The following is a description of a gene set: species: Homo sapiens Effects of SOCS3 on the transcriptional response of bone marrow-derived macrophages to IL-6. Fetal liver cells from SOCS3+/+ or SOCS3-/- embryos were used to reconstitute recipient mice. Donor derived bone marrow from these mice was differentiated to macrophages. Macrophages were either unstimulated, or stimulated for 100 or 400 minutes with 10 ng/ml IL-6. Human Gene Set: GSE411_UNSTIM_VS_100MIN_IL6_STIM_SOCS3_KO_MACROPHAGE_UP Genes up-regulated in macrophages with SOCS3: untreated versus IL6 for 100min. from publication Lang R, Pauleau AL, Parganas E, Takahashi Y, Mages J, Ihle JN, Rutschman R, Murray PJ (PMID 12754506), and this is the list of marker genes: WDR48, NCKIPSD, APBB1IP, AGL, OTULINL, SIAH1, NT5C, POLI (NCBI Gene Id 11201), ARHGEF6, TRIM65, OPA1, INTS7, IRGC, SLC43A2, PPP1R3F, S100A11, NFS1, HLA-DRB1, MRPS35, BIVM, DNASE1L3, RIC8B, ST6GALNAC3, NUDT6 (NCBI Gene Id 11162), AGRN, MAF1 (NCBI Gene Id 84232), BORCS7, TRRAP, RPS6KA5, SAV1, MDN1, PRPSAP2, RGL2, POLN, SBSN, ZNF236, FES, ORC3, USF2, EEF1AKMT2, ZKSCAN8, TBC1D19, IL4R, MYO9B, CRTC1, ZCCHC24, CHD9, USE1 (unconventional SNARE in the ER 1), TXNDC16, TESK2, C11orf68, TNK2, TUT4, PHF2, COA6, MRGPRE, C3orf33, EPB41L2, BRD9, NEB, PEX11G (peroxisomal biogenesis factor 11 gamma), HPSE, ZNF157, AMDHD2, NUDT16, DCP2, TSN, ANP32A, TCEA2, PPM1E, B3GNT8, ZNF518B, FAM120AOS, CORO1B, MED10, STX7 (NCBI Gene Id 8417), PIGN, TP53BP1, LONRF1, DNAL1, SDCCAG8, ASH1L, SCOC, AP1G2, CCDC28A, DTNBP1, EIF2AK4, ATP2A3, CSK, MAP4K5, ZNF688, TGFB1 (NCBI Gene Id 7040), SLC2A9, PUS3, SBK1 (SH3 domain binding kinase 1), ABHD11, VPS54, ARHGAP45, CYB561D1, DCXR, NDUFAF5, SLC25A28, BRAT1, ABCG1, TMEM260, TRAF3, MTMR11, CASP1, HOXB3, H2AJ, CD300LF, COX20, GALNT12, BATF, AIG1, LY9, EPOP, BMP2K, CDC23, PWP2, NFATC2IP, DYNLT2B, LIPT1, GTF2I, RELCH, LRIG2, STRN4, MDC1 (NCBI Gene Id 9656), AKAP7, TMEM185A, MLH3, RAC2, RTP4, MECP2, CHMP1B, MED12, VPS37B (VPS37B subunit of ESCRT-I), CASTOR1, SLC35B3, CDC42SE1, RBM33, CAMTA2, PBX4 (PBX homeobox 4), NPM1, MAP2K5, DHODH, SKAP1, MTG2, TFAM, GPX7, SBF2, NDST1, TTC21B, RETREG3, RNF113A, ACSS1, PHIP, PEAK1, STAG2 (STAG2 cohesin complex component), OBI1, GAN, GANC, CHD6 (NCBI Gene Id 84181), GNGT2, RDH12, ARGLU1, LAMB3, TUT1, ZNF808, AAK1, DDX5, SDHAF2, ZFP28, C4orf33, WDFY1, AHR, UBE2D1, CCDC47, TPD52, MAP4K1, MFSD8, FUCA1, CHKB, TRAF2, HYCC1, C2orf68, APOBEC3B, STX16, PCBP3, SHKBP1, GML, DDX54, ZNF354B (zinc finger protein 354B), SMAD2, TMEM100 (transmembrane protein 100), SNAI3, NSUN5, VRK2, RGS10, VASH2